The following is a description of a gene set: studied in species Mus musculus Mouse Gene Set: GOCC_CALCINEURIN_COMPLEX A heterodimeric calcium ion and calmodulin dependent protein phosphatase composed of catalytic and regulatory subunits; the regulatory subunit is very similar in sequence to calmodulin., and this is the list of marker genes: Ppp3ca, Ppp3cb, Ppp3r1, Itpr1, Ppp3cc, Ppp3r2